Given this list of marker genes MIER2, ZNF586, CLK3, RPGR, UBL3, ABR, GPC6, ATP10A, FBXL3, COQ10A, CLN8, KLHDC8A, EMX2, SLC8A1, SLITRK3, PHC2, GPHN, GUCD1, ZDHHC9, PAPOLA, SEMA5B, KLF14, SLC2A12, FGFRL1, CHD6, YTHDF3, SPRED1, SAMD14, SURF4, PALLD, PAGR1, ADGRB1, GPR85, HMGN3, ARHGEF4, MYLIP, KLHL2, FAM53A, SUN1, WDR26, MLH3, GSG1L, TMF1, PACSIN2, CABS1, PLCB4, WWP1, ZNF704, SMAD5, ZNF185, SULT4A1, ZNF518A, ATP6V0A2, TCOF1, PHF24, CTRL, APLP2, SH3GL2, STK35, SLC35F1 (NCBI Gene Id 222553), TSC1, DICER1, STRIP2, FCGR1BP, AKIRIN1, RIMKLA, RNF43, KRBA1, SLC25A35, GRIP1, ATP9B, SCOC, CD160, SELE, CSRP2, PHTF2 (NCBI Gene Id 57832), BICD2, PDE2A, ZNF20, DDX23, NEXMIF, NRBP1, PACS1, ZBTB43, RIMS4, NCAM1, SPRY2, TENM3, SPTB, PDAP1, DEPDC5, ADAMTS6, GTF2H1, RBMS3, B3GAT1, CNDP1, HAVCR2, ACTN1, GTF3C4, CTNNA2, TMPRSS11E, GALNT15, SP4, RIMS1 (regulating synaptic membrane exocytosis 1), ZNF689, ITIH6, TTC23L, RALGPS1, here is a description of the gene set: studied in species Homo sapiens Genes predicted to be targets of miRBase v22 microRNA hsa-miR-6889-3p in miRDB v6.0 with MirTarget v4 prediction scores > 80 (high confidence targets). from publication Chen Y, Wang X (PMID 31504780) Human Gene Set: MIR6889_3P